The following is a description of a gene set: species: Homo sapiens Catalysis of the acetylation of an amino acid residue of a peptide or protein, according to the reaction: acetyl-CoA + peptide = CoA + N-acetylpeptide. Human Gene Set: GOMF_PROTEIN_N_ACETYLTRANSFERASE_ACTIVITY, and this is the list of marker genes: USP22, KAT14, MCM3AP, NAA11, KAT6A, JADE1, BLOC1S1, ING3, MEAF6, NAA50, NAA60, KAT2A, BRD1, NAT8, NAA20, ATAT1, BRPF1, TAF10, CDY1, TAF9, PHF10 (NCBI Gene Id 55274), EP300, NAA80, NCOA3, CREBBP, GTF2B, NAT8B, CDY2B, SRCAP, TAF1, NAT9, PYGO2, CDY1B, KAT8, ING4, BRPF3, NAA10, TADA2A, ESCO2, NAA30, BAZ1A, ATF2, NAP1L2 (NCBI Gene Id 4674), HAT1, TAF1L, KAT5, KAT2B, BRCA2, JADE2, NAA40, CLOCK (clock circadian regulator), ESCO1, CDY2A, ARRB1, GTF3C4, KAT7, ABHD14B, NCOA1, KAT6B